Given this list of marker genes H2BC3, SYCE1, B4GALT1, CATSPER2, HSPA2, RPA1, H4C2 (H4 clustered histone 2), ATR, ATM, H2BC21, CXCR4, H2BC8 (H2B clustered histone 8), SYCP3, MLH1, H2BC1, SYCE3, TET2, SUN2, BRCA2, H4C16, TERF2, FIGNL1, RBBP8, H2AB1, SUN1, H2AJ, DIDO1, SMC3, H2AC6, H3C15, DMC1, MSH5, H2BC13, RAD51, SPAM1, TOP3A, SMC1B, ZP2, H3C8, ADAM30, H4C4, CBFA2T2, STAG3, OVGP1, H2BC17, SYCE2, PRDM9, MLH3, CATSPERG, PDPN, H4C13, H3C2, H3C14, H2BC26, IZUMO4, H2AC4, TINF2, H3-3B, H3C7, CATSPER3, H2AC8, ZP3, H4C1, H4C11, H4C15, H2BC10, SOX17, SMC1A, RPA2, MSH4, H4C14, RAD21, SYCP2 (synaptonemal complex protein 2), IZUMO2, STAG1, H2BC4, LMNB1, POT1, H2BC15, CD9, H3-4 (H3.4 histone, cluster member), SYNE2, EOMES, H3C10, CATSPER1, H2AX, HVCN1, SYNE1, H2BC6, H2BC11, H3-3A, TERF1, FIRRM, H3C11, TERF2IP, NANOG, H3C1, FKBP6, ACD, ZP4, H3C6, ADAM2, ADAM21, H2BC12L, H2AC20, H2BC5, CATSPERD, PRDM1, H4C5, SYCP1, H2AC14, H2AC19, H2BC12, MND1, H4C8, H4C6, H3C13, H2BC14, IZUMO1 (NCBI Gene Id 284359), ADAM20, IZUMO3, REC8, KCNU1, H2BC7, ZP1, BRCA1, BMP4, LMNA, SPO11, H4C12, CATSPER4, NANOS3, CDK2, RPA3, H2AZ2, H4C3, POU5F1, H2AC7, H2AC18, TEX15, H3C3, CDK4, ACR, CATSPERB, RAD51C, TFAP2C, TEX12, STAG2, NBN, PSMC3IP, H4C9, BLM, H3C12, H2BC9, MRE11, H3C4, RAD50, UBE2I, here is a description of the gene set: Reproduction species: Homo sapiens Human Gene Set: REACTOME_REPRODUCTION